Given this list of marker genes ALG6, ACVR1, HABP2, F5, F9, MTHFR, EPAS1, UBA1, PROS1, F8, SERPINC1, SERPIND1, PROC, PIGA, PMM2, F2, AKT1, MMACHC, THBD, F13A1, MTRR, PIEZO1, here is a description of the gene set: Human Gene Set: HP_DEEP_VENOUS_THROMBOSIS Formation of a blot clot in a deep vein. The clot often blocks blood flow, causing swelling and pain. The deep veins of the leg are most often affected. Deep venous thrombosis species: Homo sapiens